Given this list of marker genes SYT12, GFAP, SNORA70, MIRLET7B, ADAMTS15, CCL2, JUNB, PELO, IL1A, FAM53B, GSTO2, GTPBP2 (GTP binding protein 2), ADAMTS1, CEBPD, SEPTIN12, NPRL3, SELE, OASL, DUSP5, POLR2A, TNFSF18, ACADL, ITGA5, KCND1, BIRC3 (NCBI Gene Id 330), IER3, PHLDA1, LMCD1, TGFB1I1, PIAS2, PRAMEF12, COL6A2, ADORA2B, MT1A, LRRC18, KCNE4, KDM6B, IGF2-AS, RPS27A, ERP27, SNORA62, FOSL2, UPP2, FZD4, SLC16A8, MACF1, COL4A2, BTG2, SNORD49B, MIR455, EGR1, PEG10, ASB16, RGS1, CCRL2, ZFP36, NOX3, BMP2, MAS1, HMGA1, CCL7 (NCBI Gene Id 6354), GADD45A, ATF3, UBE2R2, NR4A3, MIR145, NOD2, FBXO9, OPTC, UST, CD93, TERC, MYMK, RCAN1, HBEGF, GRM8, IER2, PPP1R15A, DUSP6, ITPR1, EGR3, FOS, PLK2, SLC38A8, MAFF, ISY1, ADM, GABRD, FLVCR2, MIR224, SNORA61, JUN, NAT8B, RBM24, TMED6, RBM33, CRYGA, CYTIP, ARL4D, CDKL1, SLC25A25, ACSM5, WDR81, SNRNP35, FOXS1, NR4A1, SGK1, MIR143 (NCBI Gene Id 406935), PI15, CEBPB, SNORA74A (small nucleolar RNA, H/ACA box 74A), EGR2 (NCBI Gene Id 1959), SF3B1, OPN3, RND3, NR2E3, APOLD1, SLC24A4, SEMA4C, ADAMTS9, PPM1E (protein phosphatase, Mg2+/Mn2+ dependent 1E), RHBDL1, SPRY1, SPRY2, EDN1, SERPINE1, SMAD7, FERMT2, FANK1, FOSB, TNPO2, HSPA1A, TRIB1, TBX3, DUSP1, TET3, MFHAS1, SLC25A33, PTGS2, AKAP12, MSH5, NR4A2, DUSP8, ID3 (inhibitor of DNA binding 3), TNFAIP6, GPR179, SLC20A1, NPAS2, PPP1R2, SRCIN1, here is a description of the gene set: Genes up-regulated in splenocytes from Foxp3-Fusion-GFP NOD mice: T reg (FOXP3+) versus T conv (FOXP3-) cells. species: Homo sapiens The aim of this study was to quantify the impact of chimeric Foxp3-GFP protein on the Treg cell transcriptional program. from publication Darce J, Rudra D, Li L, Nishio J, Cipolletta D, Rudensky AY, Mathis D, Benoist C (PMID 22579475) Human Gene Set: GSE37605_TREG_VS_TCONV_NOD_FOXP3_FUSION_GFP_UP